The following is a description of a gene set: Human Gene Set: KEGG_MEDICUS_PATHOGEN_HTLV_1_TAX_TO_TNF_JNK_SIGNALING_PATHWAY studied in species Homo sapiens Pathway Definition from KEGG: TAX -> (MAPK8,MAPK9,MAPK10) -> JUN => MMP7 HTLV-1 Tax to TNF-JNK signaling pathway. Pathway ID: N00503. Pathway type: Pathogen. Pathway class: nt06516 TNF signaling., and this is the list of marker genes: MAPK9, MAPK8, MAPK10 (NCBI Gene Id 5602), MMP7, JUN